Given this list of marker genes DIAPH3, CDC45, LRRC75B, ERRFI1 (NCBI Gene Id 54206, ERBB receptor feedback inhibitor 1), ACSM3, MYADM, PMF1, RAD54L (RAD54 like), NSL1, CEP55, XKR5, SSC4D, H2BC18, TRAIP, NUCB1, LRRC59, ANAPC2, BRIX1, ITGB3, ANAPC11 (anaphase promoting complex subunit 11), DNAJB11, DCP1B, MARS1, SEMA4A (semaphorin 4A), NME2, FHL2, FUT11, WDR37, NUP205, MTMR1, HSPA4L, LRP8, STYK1, DNAAF4, NTF3, INPP5E, BABAM2, MATN2, PPM1J, TBC1D31, SLC6A19, CASP12, AGPAT4, CCHCR1, P2RX1, TMTC4, PIK3AP1, SAR1A, WASF3, HDAC1, ZC3HAV1L, CMKLR1, IL12RB1, G0S2, ASPM, EMD, E2F7, TAX1BP3, EML3 (EMAP like 3), TPPP3, BMPR2, AJUBA, TSPAN1, MT2A, OGFRL1, ADAM2, MAGI3 (membrane associated guanylate kinase, WW and PDZ domain containing 3), SLC12A5, E2F8, NASP, KLRC1, RAP1GAP2, PXYLP1, KRT28, PRKAG1, CASP7, RHOA, MAP7D1, PRPH, CSF2, RMDN2, EMP3, L1CAM, MTM1, PAK4, RBL2, DARS2, RASL11B, CENPH, DLGAP5, BANF2, PALB2, PALD1, BPNT2, NEK2, PICALM, LYAR, KIF2C, SUV39H2, MIS12, BORCS7, ATP8B4, FAM13C, REPS1, ACYP2, PRKAG2, NUP85, HS3ST3B1, WDHD1 (WD repeat and HMG-box DNA binding protein 1), RFWD3, GAB3, PLXDC1, EXOSC9, ANXA8, TMEM208, ZRANB3, BMAL1 (NCBI Gene Id 406), PAK6, SARS1, TTK, SEPTIN11, RCN1, ADAM8, ERI1, SPC24, RAD18, ADAMTS18, CDKN1A, NSMCE2, FIRRM, NDC80, ITGAE, SHMT1, CELF5, FOSL2, TEDC1, CENPE, CTC1 (NCBI Gene Id 80169), CCNB2, TYMS, FABP5, PPP1R2P1, NKPD1, CD200R1L, PTEN, ERGIC2, AHNAK, ZNF652, TUBA4A, CLCN5, LRRC40, TMA7, EIF4A3, NFIC, PITPNB, PASK, NUDT4, CPSF2, FBXO30, NEURL1B, COX7A2, SPINT4, SPATS2, FAM161A, CIB2, AUNIP, OIP5, MAN1C1, KIF14, BYSL, FGL2, CD86, NRM (nurim), WNT5A (NCBI Gene Id 7474), WDR38, YWHAB, PARK7 (NCBI Gene Id 113880), TTL, BCL6B, ROM1, CAPN2, TNKS1BP1, OSBPL3, SEPTIN8, CRIP1, KIF23, RTN4RL1, CEP76, CSRP2, RFTN1, RACGAP1, TMEM225, FANCB, USP1, LRRC31, HPS6, SNRPA1, DDIAS, EVX1, PADI2, here is a description of the gene set: from publication Ghoreschi K, Laurence A, Yang XP, Tato CM, McGeachy MJ, Konkel JE, Ramos HL, Wei L, Davidson TS, Bouladoux N, Grainger JR, Chen Q, Kanno Y, Watford WT, Sun HW, Eberl G, Shevach EM, Belkaid Y, Cua DJ, Chen W, O'Shea JJ (PMID 20962846) CD4+ T cells that selectively produce interleukin (IL)-17, are critical for host defense and autoimmunity1-4. Crucial for T helper17 (Th17) cells in vivo5,6, IL-23 has been thought to be incapable of driving initial differentiation. Rather, IL-6 and transforming growth factor (TGF)-β1 have been argued to be the factors responsible for initiating specification7-10. Herein, we show that Th17 differentiation occurs in the absence of TGF-β signaling. Neither IL-6 nor IL-23 alone efficiently generated Th17 cells; however, these cytokines in combination with IL-1β effectively induced IL-17 production in naïve precursors, independently of TGF-β. Epigenetic modification of the Il17a/Il17f and Rorc promoters proceeded without TGF-β1, allowing the generation of cells that co-expressed Rorγt and T-bet. T-bet+Rorγt+ Th17 cells are generated in vivo during experimental allergic encephalomyelitis (EAE), and adoptively transferred Th17 cells generated with IL-23 in the absence of TGF-β1 were more pathogenic in this experimental disease. These data suggest a new model for Th17 differentiation. Consistent with genetic data linking the IL23R with autoimmunity, our findings re-emphasize the role of IL-23 and therefore have important implications for the development of new therapies. Genes up-regulated in CD4 T cells treated with IL1B and IL6 versus those also treated with IL-23. species: Homo sapiens Human Gene Set: GSE23505_IL6_IL1_VS_IL6_IL1_IL23_TREATED_CD4_TCELL_UP